The following is a description of a gene set: A process in which a protein is transported to, or maintained in, a location within a Golgi membrane. studied in species Homo sapiens Human Gene Set: GOBP_PROTEIN_LOCALIZATION_TO_GOLGI_MEMBRANE, and this is the list of marker genes: RAB41, RAB6D, ARL5C, RAB6A, RAB6B, ARL5B, ARL5A, RAB6C